The following is a description of a gene set: studied in species Homo sapiens Any process involved in the controlled self-propelled movement of a cell that results in translocation of the cell from one place to another. Human Gene Set: GOBP_CELL_MOTILITY, and this is the list of marker genes: RHOA, CLDN1, TMEM102, PAFAH1B1, RHOF, SAXO4, TNR, IL33, RNF7, STX4, CFAP107, KIT, CEMIP, DRD2, SEMA4F, SLAMF8, MAP1B, SCAI, DAB1, ARHGEF5, UBE2B, SEMA3E (semaphorin 3E), IGFBP3, ADAM15, SCRT1, WDPCP, DST (dystonin), CADM4, LAMC1, ARHGAP35, CAMK2B, GFRA3, DCHS1, EMP2, GSK3B, SMURF2, UNC5D, CKLF, LOX, NHLH2, MIR150, NR2E1, PDGFB, IL17RC, FSHB, RHOD, SPRY2, MIR1290, ACKR4, IL10, PLCB1, FGF21, DOCK1, MARK1, EVX1, TNFSF11, CDH9, CDC42BPB, ADCY3, CTNND1, MAP3K7, MICOS10-NBL1, MIR638, NF2, SAP130, ADAMTS9, COL5A1 (collagen type V alpha 1 chain), MIR152, CTNNA2, ARX, NR4A3, VANGL2, SWAP70, FLT1, CYP1B1, PLEKHG5, SDC4 (syndecan 4), MIR92A1, ECM1, STK10, SLAMF1, MIR27B, ULK4, IGSF10, CDK1, SPECC1L, ARPC5, CPNE3, ABI2, SEMG1, BCL2, AGTR1, PTK7, HBEGF, MIR222, MMP2, TEX101, EPHA2, WNT7A, MIR196A1, CCL13, SAP30L, ADARB1, TMSB15A, CCL3L3, BMP7, FSIP2, IL12A, ANLN, ANGPT2, PTGER4, DCX, MIR223, MIR204, FOXG1, DCN, SRPX2, CDK5R1, CIMIP2C, FOXJ1, EPS8, PIK3CB, IGF1R, BRMS1L, BCAS3, VAV1, HOXA5, FOXC2, ARMC3, GAPDHS, NTNG1, DOCK5, LAMTOR2, FAM83H, IGSF8, SOD2, MIR320A, SFRP1, MKKS, CXCR2, SEMA3F, MIR133A1, TBCCD1, CRIPTO, HAS1, MADCAM1, PACRG, CFAP221, SAP30, SPRED1, MOSPD2, PADI2, C2CD6 (NCBI Gene Id 65071), TSPO, HTN1, KNSTRN, P4HB, PLET1, CCR7, SATB2, BIN2, TAFA4, ITGA2B, FADD, HMGB2, HSD3B7, DNER, ELMO1, VASH1, MMRN2 (NCBI Gene Id 79812), BEX4, GNAI2, RAP2A, HEXB, CCDC65, CFAP90, TALAM1, CCAR1, CXCL3, USP9Y, FMN2, SRGAP2, FOXE1, PIK3C2G, MIRLET7A1, CFAP210, MIR101-1, FUZ, RICTOR, CFAP251, ITGB1BP1, NRP1, PARP9 (NCBI Gene Id 83666), KIRREL3, CXCL11 (C-X-C motif chemokine ligand 11), MIR10A, DAB2 (NCBI Gene Id 1601), TGFB1, MIR338, UBE2I, SCRIB, CD9, ACVR2B, TRADD, RIBC1, DLG5, HCK, PLEC, NIPBL, MIR22, CDH20, RCC2, CTSH (NCBI Gene Id 1512), NINJ1, CDK5, MEIG1, SCARB1, RIN3, AKAP4, CCL14, SFRP2, MIR200A, FGF23, CXCR4, CDH23, ZNF703, SRGAP2C, PHACTR1, RABGEF1, CCL7, NCK1, CCL26, JOSD1, ABI1, DNAH5, NME7, AIF1, CCDC25, GK2, F10 (NCBI Gene Id 14058), CFAP141, CFAP65, ARID4A, TRIM46, SEMA5B, CELSR2, DACH1, PEX7, BBS4, TGFBR3L, ASAP3, MYOC, TMSB15B, ARHGAP5, PHACTR4, CDH11, VCAM1, CUL3, CTNNA3, PAK1, KIF2A, IL24, DUSP22, YTHDF3, GPC1, SCN11A, MYD88, FGFR1, MIR29A, NLRP12, MESP1, GPI (glucose-6-phosphate isomerase), FRMD5 (FERM domain containing 5), ITGA5, DEFA1, FOXO4, MIR379, MIR181B1, ZNF268, EFHC2, CCR10, PRKCA, DEFB131A, SLIT1, GPR183, MIR491, CARMIL3, MIR140, SLK, MACIR, PLVAP, SLC9A1, RHOG, TBX21 (NCBI Gene Id 30009), APELA, HOATZ, RIPK3, ADAM10, MIR30C2, CXCL17, TNFSF14, ITGA4, FERMT1, FAM3D, CD63, PLXND1, FOXO3, NEURL1, SEMG2, ITGA2, RHBDF1, MATN2, MIR329-1, CDH17, BMPR1A, MAP4K4, DDIT3, GARIN2, PTPRU, PIN1, FERMT2, PAK2 (p21 (RAC1) activated kinase 2), WNK1, ASPM, ENG, MRTFA (NCBI Gene Id 89880), DMTN, TBX1, CAV1, CDC42, RPL13A, RNF41, CDH4, FSTL1, EFHC1, IFNG, CATSPER3, AVL9 (NCBI Gene Id 23080), SLC22A16, SH2B1, SIX4, MIR361, NODAL, DISC1, NFATC2 (NCBI Gene Id 4773), MIR10B, DNAH6, ANXA1, PITX2, MSMP, BAG4, FUT8, KIF26A, CLXN, MSTN (myostatin), PLPP3, MINK1, TNS1, SOX9, SYDE2, EMC10, TEKT5, EDN1, GLUL, ZFAND5, STK39, MIR665, TNC, PRICKLE1, PRKCD, FLRT3, ANG, PTPRO, FGF2, PGF (NCBI Gene Id 5228), SH3RF2, SMPD3, RAB13, ARC, GRB10, STK4, STAT3, APOD, GSK3A, MIR590, CD200R1, DNAH11, LGALS9, GBA1, CABS1, S100A2, TPPP2, MIR892B, SYNE2, C1QTNF8, DEFB110, ATP8A1, MIR495 (NCBI Gene Id 574453), GPC4, NR4A1, ABL2, P2RX4, PDGFA, WNT5B, MIR497, BMPR2, EOMES, CRKL, MIR492, GNA13, MALAT1, SUN1, MMP9, PFN2, CCL23, CLDN4, POU3F3, TMSB4Y, YIF1B, PLXNB2, DUOX2, CD69, HDAC7, TNFRSF14, SLURP1, PCM1, CEP131, APOB, PIK3R1, CDH19, NKX2-1, PLG, DNALI1, CCRL2, MED23, ACVR1, SOX18, FUT10, UMOD, ANGPT1, LAMA2, ENKUR, DNAH8, ERRFI1, JUN, CCDC38, CCR3, SELE, AGTR2, MTA2, ELP5, NFE2L2, TSSK4, ONECUT2, BAMBI, MEAK7, SIRPA, LZTFL1, BMP10, CCR8, ELP6, POTEE, PODXL2, EFNA1, PAK5, MAP2K5, SEMA6A, STAT5A, KANK2, ASTN2, GREM1, CORO7, ARPC5L, SPATA13, ITGBL1, SSX2IP, CORO6, CYRIB, CMKLR1, MIR3173, PRM3, DEFB4A, SLC26A5, CXCR5, SPAG9, TPBG, CXCL9, JUP, L1CAM, ITGAL, APOE, RRAS, TTLL3, RNASE10, EPX, CFAP44, MIR23A, CFAP53, PLXNA2, ASCL2, MIR182, HSPB1, SERPINF1, GFUS, S100A9, UNC5C, CXCL2, GOLPH3, GAS8, APPL2, HES1, CSF1R, KRT2, POTEKP, PGAM4, PTPRK, PLA2G3, EVL, DPP4, MIR4500, GLI1, HAS2, GFRA1, GPLD1, SDCCAG8, BRAF, BAX, THY1, TNFAIP6, SPARC, MIR135B, CD99, SIX3, TMEFF2, TAC3, PLK2, IL23A, SLC9B1, WDR1 (NCBI Gene Id 9948), ADAMTS1, CCN2, SIX2, ROBO4, LIMA1, ABCC1, CCL21, LPXN, MIR1908, GDNF, GPER1, CX3CL1, SCRT2, CORO1C, OXSR1, CXCL1, CCR5, INS, CYGB (NCBI Gene Id 124510), ZAP70, MIR205, RBBP4, PIERCE2, FYN, JAM3, EGR3, DNAH2, PTP4A3, DUOX1, LRP12, TCAF1, LEF1, TMEM196, PHB2, LRP1, TUBGCP2, MIR21, ACTN4, EPB41L5, ZG16B, AMOTL2, GPC2, LHX1, TMEM18, F3, SDC2, TCP11L2, TAOK2, NEXMIF, PRSS3, THBS1, LYST, PTPN23, LHX6, ATP5F1B, GRAPL, LIMCH1, PIK3R3, SEMA4D, BMERB1, DEFB130B, SOX17, CRTAM, PRR5L, CALR, RBBP7, PDILT, ENPEP, IL12B, HACE1 (NCBI Gene Id 57531), CCL5, SIRT1, UNK, ZMYND8, ROBO1, ROR2, LRIG2, POMGNT2, PLXNB3, ITGB4, DNAI1 (dynein axonemal intermediate chain 1), ZP3, DSG3, CDH1, TNFRSF11A, FGF13, CITED2, ACTA2, OGT, BARHL1, PROX1, PGK2, ZRANB1, FLT4, NCKAP1L, SSH1, PDGFRB, EPHB1, PDCL2, CLDN5, STRBP, SELL, HTR6, IL16, MYH10, CLASP2, MIR26A1, MMP12, PLCG2, DEFB104A, CSF1, RHOC, PRKCQ, JAK2, CD47, BMP4, PLXNB1, IL6R, HMOX1, MYADM, ABHD2, ASCL1, PERP (NCBI Gene Id 64065), TACSTD2, OLIG3, APOA1, KLRK1, LDB2, NR4A2, IL17RA, FCER1G, MIR214, CD24, PLTP, CCL19, MIR151A, PDCD10, RSPH6A, CXCL16, MIR212, AKT1, MCTP1, CFAP54, CDH24, PIP5K1C, MIR885, VEGFC, TBXA2R, DPCD, CCDC88A, MIR20A, CCR2, RFX3, PTPRB, CAVIN1, MAFIP, NME8, MIR200C, CATSPER4, TTLL5, RNF20, TEKTIP1, ADIPOQ, LAMB1, PAK4, SPOCK2, MIXL1, PPIA, FMNL2, IL1B, SORD, CDC42BPA, SKI, C5, MIR224, ANGPT4, NHERF1, BRMS1, SHROOM2, S100P, OGDH, PF4, BCL6, TEKT1, ARSB (arylsulfatase B), EFS, SASH1, MIR133B, RTN4, HDAC2, MTCH2, CDH3, RREB1, RAB11A, CHST4, SEMA3C, CLIC4, SPMIP6, SOX14, CELSR1, AJUBA, EFNB1, RHOJ, FEZF1, PRDM14, ADORA1, ING2, CCL24, MIR185, ATM, TLR4, SIX1, TNF, CDK5R2, NANOS1, SMAD4, PPIB, SEPTIN4, CCR6, DAPK2, TTC12, LGALS8, WASF2, ITGA11, C3AR1, ALKBH1, MAZ, ITGB1, KLC3, MIR939, MDGA1, S100A7L2, AKAP12, SERPINB3, MIR505, MIR146A, GSX2, ACTBL2, LYN, FSCN2, IER2, POTEJ, ITGB7, MST1R, INPP5B, EHD4, ADAM7, P2RY12, CTNNA1, DEFB109B, SEMA4B, BTG1, DZIP1, CAMSAP3, SPACA9, HYAL2, ABI3, SPOCK3, SMIM22, BRAT1, LAMA5, MIR519D, MIR1-1, PTPN1, PLXNA4, BRK1, FSCN1, PLCG1, CXCL6, SRF, SGPL1, CXCR6, DNAH3, FLNA, PTPRJ, CDHR3, BCAR1, CIMAP1A, CORT, FGF1, EMX2, DNAAF11, TNFRSF12A, ARID5B, CEP78, MIR199A1, MYO1C, SRCIN1, PDGFRA, CDH12, PARVA, VAV2 (NCBI Gene Id 7410), CFAP276, BCL11B, PIKFYVE, ATP5F1A, DEFA4, PALLD, TERT, BST1, TUBB4B, ELP3, CCR9, JAML, GCSAM, PODN, DYNC2H1, PDGFC, MYO1G, AIMP1, SPI1, LCP1, LAMC2, RHOB, MSN, EZH2 (enhancer of zeste 2 polycomb repressive complex 2 subunit), MIR499A, LOXL2, ROBO3 (NCBI Gene Id 64221), DEFB103A (NCBI Gene Id 414325), MMP14, PIP5K1A (phosphatidylinositol-4-phosphate 5-kinase type 1 alpha), LRATD1, AZU1 (NCBI Gene Id 566), FGF22, SMAD3, KIF20B, ROCK1, MIR493, MEGF10, CRK, ACKR3, GATA2, DGKZ, DEFB104B, QRICH2, IL34, MIR451A, PINK1, DEFB114, NSMF, CBLL1, CXCR1, RACK1, FGF10, IRS2, STARD13, DNHD1, CREB3, CSF3R, ARHGEF2, TRIP6, ETS1, CCL16, SEMA5A, PRKD1, STC1, PTPRG, DUOXA2, FAM89B, KDR, EPB41L4B, KIAA0319, MIR543, CCR1, PLAT, MAP2K2, MAPK3, LGALS3, MAPRE2, ZNF609, MIR296, AUTS2, CLASP1, HSP90AA1, SDC1, TNXB, RAP2C, PHLDA2, OCLN, NAV3 (neuron navigator 3), MIR1298, RFFL, RIGI, MEOX2, ANGPTL3, BMPER, HRG, PLXNA3, HSPA8, AKT2, MIR640, MIR92B, MDM2, NAV1, PLAA, DNAH14, MIR15A, CLDN19, MIR129-1, DNAH1, CFAP57, TTBK2, RDX, RADIL, GPR15, CCR4, IL1R1, HDAC9, PRTN3, LEP, HSPA5, TUBA1A, NCKAP1, IDH2 (isocitrate dehydrogenase (NADP(+)) 2), ALOX15B, MCC, C5AR2, MIR145, DPYSL3, LRRK2, CELF3, WDR47, PKN1, SUN2, SOX8, CH25H, SNAI1, GLI3, DDT, NDN, SEMA3G, DNAH7, HGF, SINHCAF, RAB25, CFAP77, ROPN1L, YWHAE, BBOF1, DAB2IP (NCBI Gene Id 84635), FGF3, CDKL5, SMAD2, ANXA3, XCL1, FGF5, TIE1, HOXB9, CCL27, KLRC4-KLRK1, TBX5, TBX20, FIGNL2, FZD3, GPX1, DOCK10, SIN3A, PIK3C2A, SPEF1, LDHC, GNAI1, F2R, CFAP20, TTLL1, CHGA, PTN, PIK3CD, WNT5A, PTPRF, FGF17, CXCL14, MCOLN2, LDB1, ARID2, MICALL1, RAP2B, CFAP161, ANKS1A, DRC7, CLRN1, LCN2, POU3F2, CATSPERZ, ELMO3, CORO1B (coronin 1B), ADORA3, CDH18, F2RL1, MIR218-1, CXCL12 (C-X-C motif chemokine ligand 12, NCBI Gene Id 6387), TOP2B, EDNRB, JCAD, CATSPERD, DRC1, AP1AR, ARHGAP4, ADIPOR1, CCDC40, CFAP157, LRRC46, TSSK6, CTSG, CCL20, MIR448, DEFB130A, PDE4B, EFNB2, EPHA8, CCL28, EDNRA, ACTG1, CDH7, MIR193A, MIIP, ATN1, NEUROD4, F11R, FOXP1, ODAD3, EPHA1, RNH1, PLEKHO1, PF4V1, CXCR3, GNRH1, MITF, TAC1, GAB1, FBXO41, CFAP69, FGF16, ASB2, MAPK15, PDGFD (platelet derived growth factor D), IL17A, TGFBR3, SPINT2, RRAS2, ARMC12, NET1 (NCBI Gene Id 10276), TRIB1, NTRK2, ERBB4 (erb-b2 receptor tyrosine kinase 4), CEACAM6, SPAG6, CRB2, LRG1, TWIST2, YES1, ITGB6, CD40, PLXNA1, BSG, ITGA7, FAT2, CATSPER1, DOCK8, EMILIN1, KANK1, MET, PLA2G1B, GATA3, CCK, SRGAP1 (SLIT-ROBO Rho GTPase activating protein 1), ZNF304, MAPK14, MTOR, ITGAX, CD74, CDH6, ITGB2, GIPC1, TCTE1, CLN3, GPR173, XG, AGT, SLC22A14, SRP54, PTPRC, PRCP, CFAP126, NR2F2, HSPA12B, PIK3C2B, PTK2B, POC1B, C8orf44-SGK3, IRAK4, TUBB2B, PDLIM1, MIR588, SPDL1, PRSS3P2, ARPIN, ZEB2, NOG (noggin), SH3BP1, TRPV4, CASP8, CXADR (NCBI Gene Id 95792), RELN, FBLN1, CCNYL1, MIR24-1, IGFBP5, MAP2K1, INPP5F, KRT16, APC, SEMA4G, NOS3, MGAT5, NRCAM, MIR130A (NCBI Gene Id 406919), DNAI3 (NCBI Gene Id 126820), MIR138-1, AAMP, PFN4, MIR27A, CD200, CD177, BARHL2, ATOH8, MIR410, KIF14, CDH10, TMSB10, CNN2, SPHK1, ENAH, CFAP119, HIF1A, PRKG1, THBS4, ITGA1, SPEF2 (NCBI Gene Id 80192), PRPF40A (pre-mRNA processing factor 40 homolog A), FGFBP1 (fibroblast growth factor binding protein 1), ABL1, PECAM1, MIR137, PLA2G7, CLDN3, TACR3, ADGRG3, MEGF8, PSG2, COL1A1, GBF1, TWIST1, TYRO3, JAGN1, BBS2, MIR424, SOS1, LRRC15, CAMK2A, PPARD, TBC1D21, AQP1, GDF15, DLL4, USP33, FAM83D, TNFSF18, MMRN1, MARK2, TGFB2, PRKD2, GNA12, RIPOR2, GPM6A, POTEF, ARHGDIB, TEKTL1, CER1, NBL1, MIR15B, DNAAF4, AKT3, STON1, SHTN1, DRD1, PTK2, GJA1, CCL4L2, ID1, ARHGEF16, NARS1, FERMT3, SPN, SPEM3, TESK1, PDPN, ZMIZ1, CCL22, CFL1, S1PR1, MIR9-1, PYCARD, SOX1, IQSEC1, VIL1, DNAH17, HDAC1, FER, MIR302C, RSPH4A, IRGC, CGA, ROPN1B, MIR29C, PHPT1, SEMA6B, MIRLET7G, CD300A (NCBI Gene Id 11314), VPS13A, EXT1, MYCNOS, CARMIL1, HTR2B, BCR, DUSP10, PPM1F, IQUB, IL4 (NCBI Gene Id 3565), ACVRL1, STMN1, MIR551A, FZD4, CFAP45, TRPM2, LDLRAD4, SOX10, MAPRE1, MIR487B, CD151, DMRT1, PTEN, APBB2, NRG3, SPAG8, MIR208A, PKN3, SRC, RAC2, DEFB103B, PXN, MMP28, SYK, CFAP95 (NCBI Gene Id 138255), ARHGEF7, ASTN1, MAGI2 (membrane associated guanylate kinase, WW and PDZ domain containing 2), NDE1, FGF9, CFAP52, GBX2, SMAD7, SH3D21, STAT1, CIB1, ST3GAL4, SERPINE2, H2BC1, ACTR3, IQCG, LRP5, PATZ1, TJP1, CD81, NTRK3, PPP1R9B, EPHA3, WAS, HOXA7, ADA (NCBI Gene Id 100), TRPM4, CUL5, MYO18A, FAP, AKAP3, CEP85L, EFCAB9, MIR520D, NUMB, PRKCE, SAA1, CCL25, PIK3CG, PRAG1, LRP8, CCDC159, TP53INP1, CEP128, SEMA4A, FOXB1, FGR, CDKN1B, SORL1, TEKT3, TNFSF12, FAT1, IL6, ITGB5, FBN2, PPARG, GSTP1, SST, TIMP1, MIR494, CFAP58, TLE6, CSPG4, S100A7A, DNAH9, DCDC2, ASH1L, TACR1, ZC3H12A, ITGA3, ARPC3, DDRGK1, RERE, PLEKHG3, PRKCI, ADRA2A, SYDE1, CEND1, FPR2, SELENOK, MIR503, EFHB, MTUS1, CCL2, XCL2 (X-C motif chemokine ligand 2), NOTCH1, CYP19A1, CEACAM1, ITGA6, LAMA1, CCDC125, IFITM1, MARVELD3, TACR2, FAM114A1, DEPDC1B, ARHGAP18, KIAA0319L, KRT5, VTN, JAM2, ROCK2, CDH5, RIC8A, PHOX2B, MIA3, APCDD1, DDIT4, VEGFA, ITGB3, PFN1, EPPK1, HMGB1, NKX6-1, FOLR2, MSX2, GPSM3, PSEN1, CAP1, FES, ARL13B, OPHN1, APPL1, CDH22, PACSIN2, CD44, CCBE1, S100A8, PEAK1, DAPK3, PPP3CA, LCK, MBOAT7, S100A11, TIRAP, EPHA4, CEP85, CX3CR1, ADGRB1, MIR210, RIN2, USP45, MIR30A, INTS13, ONECUT1, MIRLET7F1, STAP1, FOXF1, PEX5, PODXL, NTN1, ISL1, DNAAF2, GTPBP4, FGF18, CXCL10, GDF2, PLXNC1, CD2AP (NCBI Gene Id 25916), TREM2, FGF4, WASHC1, NKD1, DEFB124, PAK3, PDPK1, BBS1, RAPGEF2, TPM1, ALOX5, ABHD6, VAV3, CXCL5, S100A7, ADGRL3, MIR200B, MACF1, PBXIP1, SEMA3B, PTK6, EGF, CDH8, MIR181D, AMOTL1, NTN4, FBXO5, LARGE1 (NCBI Gene Id 9215), TTLL6, FUT1, SH3KBP1, FLT3, BIN3, GPC5, MYOCD, SIN3B, POSTN, CALCA, MIR143, TNFAIP1, CCN3, PREX1, AIRE, FAM110C, FLRT2, INSR, CNTN2, CEP43, LTB4R2, FMNL3, SLIT3, ZNF580, GPR15LG, CXCL13, ADGRG1, RECK, ARF4, VCAN, SERPINE1, GPC6, ILK, NCK2, GRN, EMILIN2, CCL17, ADGRA2, CCDC39, TMEM232, SP100, BVES, CFAP61, WDR62, CORO1A, FOLR1, DSTN, SEMA6C, PIP5KL1, ANO6, LAMA4, TTLL9, S100A12, MIR19A, DRGX, OVOL2, FN1, MISP, TIAM1, CCL8, FILIP1, STRIP2, PKN2, STK24, TREM1, JAG1, GLIPR2, NUS1, IGF1, SERPINB1, LYVE1, MIR128-1, WWC3 (WWC family member 3), FGF19, ZMYND12, TNFRSF18, NRP2, WNT4, TUBB2A (tubulin beta 2A class IIa), CFAP97D1, MPP1, SULF1, ACTB (NCBI Gene Id 60), SMO, ATP1B2, USP9X, DNAJA4, ARTN, CASS4, RET, CDH2, FOXN1, MIR483, ATOH1, EFCAB6, NOX1 (NADPH oxidase 1), MMP7, FGF20, CENPV, GADD45A, DUSP1, PHLDB2, F7, GRB7, DBH, IFT81, ACE, DUSP3, LGMN (legumain), EPHB4, NEDD9, GAS2L2, PPBP, PRKX, PDCD6, TMSB15C, MIR132, POU4F1, CFAP47, ADAM8, ADGRE2, FBXO45, MIR2355, SLIT2, SPAG16, CIMIP2A, ACKR2, IQCF1, C1QBP, MEF2C, SCG2, CSF2, RUFY3, PRSS55, CFAP206, BST2, TMEM201, MIR31, PEAK3, GCSAML, NGFR, CATSPERE, PTPRT, VDAC3, LMO4, SYNJ2BP, RGCC, MCU, TTLL8, LPAR1, ELMO2, PARD6B, MIR362, MIR711, ABCC8, EPPIN, TMIGD3 (transmembrane and immunoglobulin domain containing 3), GCNT1, MIR34A, CAPN7, CDK6, ARPC2, SPNS2, MIR335, LMNA, DOCK2 (dedicator of cytokinesis 2), PROP1, FFAR2, ELANE, SUDS3, MYH9, TGFBR2, LRCH1, SRGAP3, SMOC2, SBDS, NEO1 (neogenin 1), IGFBP6, CLEC14A, ACVR1C, SPMIP11, PTPRR, DNAAF6, SELP, DEFB133, TGFBR1, ACVR1B, DNAH10, DEFB1, SP1, AFDN, VAX1, WASL, TEKT4, SCYL3, COL3A1, MIR16-1, ARID4B, PML, DUSP21, PTPN11, MIR206, PIERCE1, WWC2, OR51E2, VSTM4, PAXIP1, FAM107A, DOCK7, VEGFB, TCAF2, SLIRP, POTEI, ATP1A4, NUP85, MIEN1, SEMA7A, CCL18, INSM1, P2RY1, ARRB2, RAC1, BMP5, FMNL1, ACTL8, CFAP144, AXL, PPP2R3A, KRIT1, ICAM1, EPHB3, MAP2K3, GARIN3, CHL1, FGF7, APP, STK26, AGER, ADAM9, MNS1, SEMA6D, LGR6, FAT3, DAG1 (dystroglycan 1), INSL3, CNR2, CCL3, CDH26 (cadherin 26), ITGA9, SDCBP, ADAMTS12, MIR126, DNM1L, TNFAIP3, MIR181A2, CHST2, ARHGEF39, MMP3, TAC4, VCL, SEMA3A, ENPP2, ADD2, ITGB8, CYP7B1, CCN4, SPMIP9, SGK3, AKIRIN1, CSNK2B, S100A14, IL27RA, RPS19, GCNT2, GPNMB, CERS2, CXCL8, SEMA3D, SH3RF1, NEXN, SLC8B1, GAS6, RARRES2, TOR1A, RAC3, DCC, TNN, FGFR4, XCR1, CLEC7A, RASGEF1A, CD300H, ARHGAP24, AMOT, CFAP43, DEFA1B, KITLG (NCBI Gene Id 780897), NF1, FEZF2, CCKAR (NCBI Gene Id 886), MYLK, CATSPER2, PTP4A1, FUT9, PAX6, FGF8, MIR221, APOH, DDR1, CCL15, TMIGD1, VEGFD, FGF6, MCAM, NRTN, XBP1, ADAM17, EPHB2, JMY, BMP2, FOXC1, DPEP1, DIXDC1, LRRC23, DAAM2, SFTPD, HDAC5, CDH13, SPOCK1, ADTRP, RIPOR1, SYNPO2, TLX3, CARMIL2, B4GALT1, LAMA3, CD248, GPC3, DLC1, SLC9C1, CTTN, HRAS, MYSM1, APC2, PLAU, TET1, NTNG2, FUT7, SMCP, CCL11, HDAC6, SEPTIN14, SPEM1, LBP (lipopolysaccharide binding protein), CDH15, TMF1, MIF, CCDC146, SVBP, GPR18, SOCS7, MIR376C, DDX4, FSCN3, RSPH9, CCDC141, PIK3CA, BDKRB1, ARF6, IQGAP1, TMSB4X, SELPLG, MIR149, C5AR1, MIR449A, MIRLET7B, CD34, CTNNB1 (NCBI Gene Id 1499), PTPRM, NDNF, SLC9B2, CAMK1D, PTGS2, MIR29B1, RIBC2, FUT3, KCTD13, MECP2, TRIM32, ARMC2, PEX13, MIR19B1, TNP1 (NCBI Gene Id 7141), SGK1, VRK1, MGAT3, CD99L2, STAT5B, FUT4, ING1, CFAP46, TBC1D24, KIF9, WWC1, SPMIP10, SLC12A2, HHIPL1, NTF3, GP2, GDF6, KLF4, ITGAV, TRIM55, MERTK, TEK, TPGS1, ATP2B4 (NCBI Gene Id 54594), MIR342, LIMD1, DOCK4, FKRP, HAND2, EDN2, TEKT2, DDR2, NDEL1 (NCBI Gene Id 81565), NPHP4, CCL4, CCL1, CHRD, NDRG4, SHH (NCBI Gene Id 6469), CFAP68, RAB1A, ROPN1, CCN1, NISCH, SEMA4C, MIR93, SNAI2, EGFR, NKX2-3, MAPK1, MDK, ACAP3, TTC21A, OSBPL8, USP17L2, SPMIP8, SRGAP2B, SDC3, AGO2, PRSS37, EDN3, CARD10, VSIR